Given this list of marker genes Ptprf (protein tyrosine phosphatase receptor type F), Tnr, Map2k1, Ptprs, Inpp5f (NCBI Gene Id 79372), Rtca, Nrg1, Grn, Ntrk3, Ndel1, D130043K22Rik, Ptn, Neo1, Scarf1, Igf1r, Pum2, Rtn4rl1 (reticulon 4 receptor-like 1), Fkbp1b, Kremen1, Map2k2, Xylt1, Braf, Cntf (NCBI Gene Id 12803), Omg, Flna, Rgma, Adam17, Klf4, Pten, Lrp1, Rtn4r, Lrig2, Stk24, Epha4, Cers2, here is a description of the gene set: Any process that modulates the frequency, rate or extent of axon regeneration. studied in species Mus musculus Mouse Gene Set: GOBP_REGULATION_OF_AXON_REGENERATION